The following is a description of a gene set: Seizures presenting with an emotion or the appearance of having an emotion as an early prominent feature, such as fear, spontaneous joy or euphoria, laughing (gelastic), or crying, (dacrystic). These emotional seizures may occur with or without objective clinical signs of a seizure evident to the observer. Human Gene Set: HP_FOCAL_EMOTIONAL_SEIZURE species: Homo sapiens Focal emotional seizure, and this is the list of marker genes: SLC25A22, CNTNAP2, PLCB1, AHDC1, PIGA, KCNQ2 (potassium voltage-gated channel subfamily Q member 2), SCN2A, TBC1D24, PHGDH, EIF4A2, GRIN1, MTHFS, SLC38A3, SCN1A, NGLY1, SMO, PACS1, SLC12A5, GLI3, KCNT1